The following is a description of a gene set: Human Gene Set: HARALAMBIEVA_PBMC_M_M_R_II_AGE_13_16YO_STIMULATED_VS_UNSTIMULATED_3_TO_7YR_POST_TOP_DEG_UP Genes up-regulated in peripheral blood mononuclear cell stimulated vs unstimulated in children (13-16) after exposure to M-M-R II, time point 3 to 7Y. Comment: top differentially expressed genes, full set of 1080 avail in Suppl Materials species: Homo sapiens from publication Haralambieva IH, Oberg AL, Ovsyannikova IG, Kennedy RB, Grill DE, Middha S, Bot BM, Wang VW, Smith DI, Jacobson RM, Poland GA (PMID 23658707) Immune responses to current rubella vaccines demonstrate significant inter-individual variability. We performed mRNA-Seq profiling on PBMCs from high and low antibody responders to rubella vaccination to delineate transcriptional differences upon viral stimulation. Generalized linear models were used to assess the per gene fold change (FC) for stimulated versus unstimulated samples or the interaction between outcome and stimulation. Model results were evaluated by both FC and p-value. Pathway analysis and self-contained gene set tests were performed for assessment of gene group effects. Of 17,566 detected genes, we identified 1,080 highly significant differentially expressed genes upon viral stimulation (p < 1.00E(-15), FDR < 1.00E(-14)), including various immune function and inflammation-related genes, genes involved in cell signaling, cell regulation and transcription, and genes with unknown function. Analysis by immune outcome and stimulation status identified genes (p <= 0.0006 and FDR <= 0.30) that responded differently to viral stimulation in high vs. low antibody responders, including major histocompatibility complex (MHC) class I genes (HLA-A, HLA-B and B2M with p = 0.0001, p = 0.0005 and p = 0.0002, respectively), and two genes related to innate immunity and inflammation (EMR3 and MEFV with p = 1.46E(-08) and p = 0.0004, respectively). Pathway and gene set analysis also revealed transcriptional differences in antigen presentation and innate/inflammatory gene sets and pathways between high and low responders. Using mRNA-Seq genome-wide transcriptional profiling, we identified antigen presentation and innate/inflammatory genes that may assist in explaining rubella vaccine-induced immune response variations. Such information may provide new scientific insights into vaccine-induced immunity useful in rational vaccine development and immune response monitoring., and this is the list of marker genes: SIGLEC11, OLR1, PPIC, CCL18, SERPINE1, TREM1, CCL23, SLC39A8, TNFRSF12A, FFAR4, ENPP2, FN1, AQP9, SPRED1, IL1B, TMEM52B, CXCL6, TIMP4, FAM135B, DLC1, NRP1, ARRDC4, TMTC1, GNG12, SHROOM4, SERPINA1, SPINT1, LYVE1, SGMS2, PROCR, TNFAIP8L3, PPP1R14C, S1PR3, PCOLCE2, VSIG4, B3GNT5, FAM20A, PDPN, MLXIPL, ARHGEF28, CLEC1A, FGD5